Given this list of marker genes DMD, LPL, ALDH3A1, HSPA1B (heat shock protein family A (Hsp70) member 1B), MEST, MAP2K6, HMOX1, GSTA4, NNMT, RGCC, IGFBP7, CALM1, COL15A1, KCNK1, NMU, CADM1, TPBG, SLC16A3, MARCKS, BAG1 (NCBI Gene Id 573), ANP32A, CRLF1, NQO1, ID3, COL3A1, TPM1, here is a description of the gene set: species: Homo sapiens Human Gene Set: WEINMANN_ADAPTATION_TO_HYPOXIA_UP Tumor hypoxia is an adverse prognostic factor. In a recent study, we could demonstrate that cyclic hypoxia selects for hypoxia-tolerant tumor cells, which are cross-resistant to other stimuli of mitochondrial death pathways. In contrast, sensitivity of the cells to death-receptor ligands was mainly not affected. The aim of the present study was to further elucidate cellular changes induced by cyclic hypoxia and to identify alterations in gene expression pattern upon hypoxic selection by means of DNA-microarray analysis. Our data reveal that cyclic hypoxia resulted in the selection of cells with resistance to doxorubicine and radiation. Furthermore, hypoxic selection was accompanied by constitutive changes of the gene expression pattern with downregulation of 156 and upregulation of genes. Most of the differentially regulated genes were involved in cellular responses to hypoxia and reoxygenation. While many of the genes that were downregulated upon hypoxic selection represent genes that are usually upregulated by acute hypoxia, the genes that were upregulated represent genes that are involved in stress resistance and anti-apoptotic signalling. Most importantly, hypoxic selection was not associated with changes of single apoptosis relevant genes, but with alterations in gene expression levels of a wide variety of genes indicating a more complex adaptation process. from publication Weinmann M, Belka C, Güner D, Goecke B, Müller I, Bamberg M, Jendrossek V (PMID 15897868) Genes most up-regulated in hypoxia tolerant NCI H460 cells (lung cancer).